The following is a description of a gene set: studied in species Homo sapiens The process pertaining to the initial formation of a trachea from unspecified parts. The process begins with the specific processes that contribute to the appearance of the discrete structure and ends when the trachea is recognizable. The trachea is the portion of the airway that attaches to the bronchi as it branches. Human Gene Set: GOBP_TRACHEA_FORMATION, and this is the list of marker genes: MAPK1, CTNNB1, MAP2K2, BMP4, MAPK3, MAP2K1, TGFBR2